The following is a description of a gene set: electronically inferred by orthology from the curated human pathway Reactome Pathway: Synthesis of substrates in N-glycan biosythesis part of: Biosynthesis of the N-glycan precursor (dolichol lipid-linked oligosaccharide, LLO) and transfer to a nascent protein studied in species Mus musculus This event has been computationally inferred from an event that has been demonstrated in another species.<p>The inference is based on the homology mapping from PANTHER. Briefly, reactions for which all involved PhysicalEntities (in input, output and catalyst) have a mapped orthologue/paralogue (for complexes at least 75% of components must have a mapping) are inferred to the other species., and this is the list of marker genes: Nans, Nagk, St3gal5, Gnpnat1, St8sia3, Nudt14, Nanp, Amdhd2, Neu1, St6galnac1, Neu3, St3gal2, Renbp, Slc35c1, Cmas, St6galnac4, St8sia4, Neu4, Gfpt2, Gmppb, Npl, St3gal3, Neu2, St8sia2, St6galnac3, St6gal2, Fpgt, St3gal4, St6galnac2, Dolk, St8sia5, Gmppa, St6galnac6, Fuom, Gfus (GDP-L-fucose synthase)